Given this list of marker genes Pycard, Aqp5, Aldh9a1, Crtc2, Kcns2, Crtc1, Tdo2, Kcnc4, Kctd10, Spast, Mcoln1, Vwa1, Prmt8, Abca3, Kcnc1, Slc1a2, Mat1a, Upb1, Kcnc2, Kctd7, Prnp, Ugt2b1, Sod2, Prf1, Kctd21, Itln1, Kcng3, Cth, Card11, Ikzf4, Kcns1, Aldoa, Ssbp1, Steap4, Vps35, Ehd3, Fus, Kcnn4, Tgm2, Atl2, Jmjd6, Kcng4, Hprt1, Kctd8, Mpp2, Aqp11, Zfp746, Ripor2, Ryr3, Sgtb, Samd1, Blm, Kcna4, Kctd19 (potassium channel tetramerisation domain containing 19, NCBI Gene Id 279499), Tifa, Golga2, Itpr1, Peg10, Mif, Polq, Atl1, Ninj1, Gls, Slc1a5, Als2, Vstm5, Mip, Iapp, Nlrp1b, Evl, Kctd3, Kcnd3, Kcnrg, Hcn1, Kctd5, Rnf112, Itpr3, Letm1, Mospd2, Kcnc3, Aldh1a2, Cep57, Card9, Kcnt1, Nlrp3 (NCBI Gene Id 216799), Tnfaip1, Adcy8, Ripk2, Prmt1, Atl3, Cby1, Arc, Acaca, Chmp2a, Kctd1, Tk1, Gbp5, Gm12250, Kctd4, Vasp, Elavl1, Sigmar1, Prph2, Bcl10, Pnpt1 (NCBI Gene Id 71701), Kcns3, Shmt2, Kcnd2, Mapt, Mlkl, Kcna3 (NCBI Gene Id 269476), Kctd9, Ehd4, Alox5ap, Trim72, Pxdn, Kcnd1, Kctd16, Sycp1, Apip, Sgta, Kctd12, Acot13, Gnmt, Samhd1, Trpa1, Shkbp1, Kcnf1, P2rx7, Trpm2, Tmem120a, Kcng1, Calhm1, Osbpl2, Gsdmd, Kcna1, Kctd15, Kcna2, Aqp4, Ugt1a1, Kctd11, H2-M3, Bend3, Trpm4, Trpv5 (transient receptor potential cation channel, subfamily V, member 5), Kcnb2, Zbtb1, Trpv6, Kcna10 (potassium voltage-gated channel, shaker-related subfamily, member 10), Me1, Mbl1, Dnm1, Cyren, C9, Hsd17b10, Kctd2, Tmem70, Pkm, Kctd6, Pdcd6ip, Aqp2, Rnf135, Rs1, Kcna7, Clybl, Comp, B2m, Sub1 (NCBI Gene Id 20024), Prnd, Cbr4, Kctd13, Ect2, Kcnj2, Trpv1, Trpm7, Kcna5, Appl2, Rbmxl1, Ryr1, Pkd2l1, Kcnb1 (NCBI Gene Id 16500), Nlrp1a, Dele1, Acacb, Thg1l, Nacc2, Alad, P2rx3, Kcnj12, Micu1, Shmt1, Kcnv1, Nlrc4, Aldh1a3, Rom1, Basp1, App, G3bp2, Trp53bp1, Crtc3, Pkd2, Kcna6, Cryz, Kcnv2, Gria3, Ehd1, Lzts3, Otol1, Glra3, Usp16, Scara5, Nlrp6, here is a description of the gene set: Mouse Gene Set: GOBP_PROTEIN_HOMOOLIGOMERIZATION The process of creating protein oligomers, compounds composed of a small number, usually between three and ten, of identical component monomers. Oligomers may be formed by the polymerization of a number of monomers or the depolymerization of a large protein polymer. species: Mus musculus